The following is a description of a gene set: MITF regulates biogenesis of organelles such as the lysosome and endosomes through its regulation of components of the V-ATPase that is required for organelle acidification and function. MITF-dependent targets also contribute to autophagy when cells are stressed for nutrients. MITF additionally controls expression of the lysosome-resident acid ceramidase ASAH1 that has roles in sphingolipid metabolism and cellular proliferation in melanoma. part of: MITF-M-dependent gene expression species: Homo sapiens Reactome Pathway: Regulation of MITF-M-dependent genes involved in lysosome biogenesis and autophagy, and this is the list of marker genes: ATP6V1G1, ATP6V0D1, ATP6V0A1, ATP6V1A, ATP6V1C1, ATP6V0C, ATP6V0E1, ATP6V1E1, ATP6V1H, ATP6AP2, ASAH1, MITF, ATP6V1D, ATP6V0E2, ATP6V1B2, ATP6V1F, ATP6V0B